The following is a description of a gene set: studied in species Homo sapiens mouse primary BMDCs were stimulated with tlr ligands and gene expression changes were profiled on Affymetrix arrays Genes down-regulated in comparison of dendritic cells (DC) stimulated with poly(I:C) (TLR3 agonist) at 0.5 h versus DC cells stimulated with Pam3Csk4 (TLR1/2 agonist) at 0.5 h. from publication Amit I, Garber M, Chevrier N, Leite AP, Donner Y, Eisenhaure T, Guttman M, Grenier JK, Li W, Zuk O, Schubert LA, Birditt B, Shay T, Goren A, Zhang X, Smith Z, Deering R, McDonald RC, Cabili M, Bernstein BE, Rinn JL, Meissner A, Root DE, Hacohen N, Regev A (PMID 19729616) Human Gene Set: GSE17721_POLYIC_VS_PAM3CSK4_0.5H_BMDC_DN, and this is the list of marker genes: NMNAT3, PIK3C2A, UPF3B, NUDT3, CDADC1, RNF128, RARS1 (NCBI Gene Id 84715), FBXW7, USP25, IFNAR2 (interferon alpha and beta receptor subunit 2), MAFG, TRIM26, FCER1A, MPEG1, EPHA6, USO1, ZNF276, PTBP1, UBE2N, REEP2, ADAMTSL5, OSBPL11, PFN1, OAS2, STARD3NL, AGTRAP, SAP30, MMADHC (NCBI Gene Id 27249), SYNGR1, TRIM2, TAL1, DLD, CHIC2, PRDX6, HSPA9, GDE1, CDIP1, FBXW11, ANGPTL2, HADHA, R3HCC1, XPO4, ELP3, KCNK13, C6orf62, ARHGAP35, ATAD2B, RDH13, RP2 (RP2 activator of ARL3 GTPase), RIPK4, TRPV4, ADAT1, TARDBP, IQSEC1, LMAN1L, RPS3A, DENND4B, MTFR1, DIS3, SLC25A30, ARFRP1, TEC, ANKRA2, PARP12, KANSL1L, IREB2, ELOVL7, FGL2, PTGER2, EHBP1L1, PES1, PGAM5, HAS3, CCDC71L, NCOR1, H2BC5, MUC1, C6orf120, AADAT, TP53INP2, GAST, SLC39A11, FTL, NANOG, KAT2B, ELAC2, DDHD2, PHLDB1, SLF2, NFYA, NCOA6, SLC6A2, MTERF3, GALK1, SENP2, MGAT2, CCNQ, PTPRE (protein tyrosine phosphatase receptor type E), MRM3, ADAM2, CAV1, BECN1, ANKH, CCL20, TMEM9, ELK4, CCL13, NR2F1, SAE1, SYP, KCNN4 (NCBI Gene Id 3783), FASTKD5, RASAL3, POLM, TSPAN4, CHD7 (chromodomain helicase DNA binding protein 7), MARCHF7, EIF3L, TSHZ1, IFT81, KBTBD2, BCAS2, CUTA, AHCTF1, CDC42SE1, PRRC1, RNFT1, SC5D, IL10RB, MGAT4C, ACVR1, UNC13B, UBC, AGAP3, ME1, RIF1, CAMK2A, FKBP11, ZMIZ1, LAPTM4A, FBXO11, RXRA, E2F8, ENTPD1, SUN2, IL6ST, C5orf15, C1R, ATF1, ERBIN, MTMR14, UBE2D1, TEN1, PCSK2, UBE2O, TBK1, JMY, PNKD, ELOF1, SRGAP1, PPBP, PTOV1, PRPF38B, RBL1, AGL, KIAA2013, LTBP3, TTC1, CST7, ESCO1, IFT70B, VPS35, AKAP8L, RIN2, CPPED1, TCAP, EDEM1, EIF4EBP2, WBP2, POLG, IFITM2, USP15, RPL3L, RABEPK, SP7, PTPRS, DNAJB9 (NCBI Gene Id 4189), MAST2, RALGDS, LAMA3, GPNMB, SUPT20H, PTGR1, NAT2, NSF, CRTAP, RNF44, VRK2, DLG3 (NCBI Gene Id 89363), BNIP2